The following is a description of a gene set: Human Gene Set: chr5p14 studied in species Homo sapiens, and this is the list of marker genes: PRDM9, GCNT1P2, TRPC6P6, HSPD1P1, RNU6-738P, LINC02241, PMCHL1, UBE2V1P12, HSPD1P15, CDH9, PURPL, LINC02239, CDH18-AS1, LINC02103, CDH18, CDH12, ADH5P5, LINC02228, LINC02146, CCNB3P1, DPPA3P12, RN7SL58P, ENSG00000308840, AKTIPP2, LINC02899, BTG4P1, RNU6-909P, CDH10, LINC02100, PTPN11P4, RNU4-43P, MSNP1, LINC02109, RNU6-374P, RPL32P14, LINC02211, GUSBP1, TRPC6P9